The following is a description of a gene set: Human Gene Set: HP_CHIARI_MALFORMATION Chiari malformation Chiari malformation consists of a downward displacement of the cerebellar tonsils and the medulla through the foramen magnum, sometimes causing hydrocephalus as a result of obstruction of CSF outflow. studied in species Homo sapiens, and this is the list of marker genes: GTF2IRD2, SH2B1, CDC45, PEX11B, NOTCH3, PAX2, IL11RA, KMT2D, RNU4-2, H3-3A, DNAJC30, PTH1R, TMEM94, TGFBR1, RFC2, POLR3A, CTSK, FGFR1 (fibroblast growth factor receptor 1), GTF2IRD1, POR, RAD51, PIK3CA, GTF2I, MAF, EP300, KANSL1, SETD2, TBL1XR1, PPP1CB, DHCR7, RFWD3, FGFR2, DACT1, TMEM270, PORCN, PHEX, DKK1, NFIA, CREBBP, NFKB2, PIEZO2, FUZ, TBL2, HES7, ELN, NONO, EIF4H, SON, MAP3K7, SPRED1, CHD4, DHDDS, SLC30A7, HRAS, NOTCH2, SKI, TONSL, CSF1R, SC5D (NCBI Gene Id 6309), METTL27, VPS37D, ZEB2, RRAS2 (RAS related 2), MBTPS2, NOVA2, LIMK1, BICRA, HMGA2, STAT3, SLC39A14, SALL1, PLAAT3, DNMT3A, DPF2, CWC27, PTCH1, MAN2B1, TRPM3, KDM6A, SMARCA2, STX1A, SF3B2, LEMD3, KCNH5, FOXF1, FANCI, MLXIPL, POLR3B, BUD23, VANGL1, TAOK1, BAZ1B, PPP1R12A, FLNA, CLIP2, GNAQ, FKBP6, NCF1, STAG1, RECQL4, FGFR3, TGFBR2, ERF, SMO, KRAS, MKS1, FBN1, SETBP1, SIK3